Given this list of marker genes USP9X, ATXN3, USP7 (ubiquitin specific peptidase 7), BAP1, USP47, USP1, USP10, USP16, USP15, here is a description of the gene set: Human Gene Set: GOBP_MONOUBIQUITINATED_PROTEIN_DEUBIQUITINATION species: Homo sapiens The removal of the ubiquitin group from a monoubiquitinated protein.